Given this list of marker genes NAA15, NAA16, SERINC2, FNTB, NUPR1 (NCBI Gene Id 26471, nuclear protein 1, transcriptional regulator), PDCD5, BRPF1, FNTA, SERINC1, NAA25, BCAS3, here is a description of the gene set: Human Gene Set: GOMF_ACETYLTRANSFERASE_ACTIVATOR_ACTIVITY species: Homo sapiens Binds to and increases the activity of an acetyltransferase, an enzyme which catalyzes the transfer of an acetyl group to an acceptor molecule.